Given this list of marker genes Prkg1, Otud1, H2-Eb2, Dhdds, Nbr1, Trps1, Xirp2, Tut4, Uspl1, Pawr, Frmpd4, Casp12, Stag2, Klhl8, Ugp2, Pter, Lrrcc1, Ehmt1, Rnf138, Slc9a6, Meioc, Paqr5, Rps6kb1, Snx27, Ranbp3, Stt3b, Foxb1, Rilpl2, Aco2, Arfgap3, Srek1, Rb1cc1, Plagl1, Dnajc5b, Atrnl1, Dennd1a, Tdrd7, Fubp1, Krit1, Sat1, Unc79, Rorb, E2f3, Sall2, Mcm5, Spata13, Herpud2, Epn2, Ino80d, Bhlhe22, Klhl2, Jun, Synpr, Cckbr, Onecut2, Rhobtb3 (Rho-related BTB domain containing 3), Prmt6, Uba6, Vps35, Epm2aip1, Limch1, Sertad4, Ube2d2b, Zfp945, Mbnl1, Zfp160, Clca2, Pik3ca, Slitrk5, Rimklb, Ranbp3l, Ube2t, Plat, Macir, Irf2bp2 (NCBI Gene Id 672960), Sorcs3, Rbms3, Tex11, Rsbn1l, Tinagl1, Pex13, Slc24a2, Adam10, Hbs1l, Acss3, Pkn2, Ppp4r4, Cipc, Zfp975, Alpk3, Adamts5, Slc25a32, Crebrf, Lif, Fubp3, Kcnd2, Phf21b, Rnf121, Ahsg, Sgcb, Zfp37, Phf24, Seh1l, Kcnh5, Hepacam, Chodl, Uchl5, Ccdc62, Lekr1 (leucine, glutamate and lysine rich 1), Borcs7, Clic6, Cpeb2 (cytoplasmic polyadenylation element binding protein 2), Bach2, Rag1, Lipo2, Ckap2, Gpr21, Thsd7a, Rbfox1, Tab2, here is a description of the gene set: from publication Chen Y, Wang X (PMID 31504780) species: Mus musculus Genes predicted to be targets of miRBase v22 microRNA mmu_miR_3071_3p in miRDB v6.0 with MirTarget v4 prediction scores > 80 (high confidence targets). Mouse Gene Set: MIR_3071_3P